Given this list of marker genes Pla2g4f, Osbpl10, Pla2g2f, Pla2g2d, Pla2g5, Lpcat4, Pla2g12a, Osbpl5, Pla1a, Pla2g1b, Pla2g2e, Pla2g4d, Pla2g2a, Pla2r1, here is a description of the gene set: This event has been computationally inferred from an event that has been demonstrated in another species.<p>The inference is based on the homology mapping from PANTHER. Briefly, reactions for which all involved PhysicalEntities (in input, output and catalyst) have a mapped orthologue/paralogue (for complexes at least 75% of components must have a mapping) are inferred to the other species. part of: Glycerophospholipid biosynthesis Reactome Pathway: Acyl chain remodelling of PS species: Mus musculus electronically inferred by orthology from the curated human pathway